Given this list of marker genes OTUD6B, EIF4E2, EIF4A2, EIF4G3, EIF4EBP3, NCBP2, NCBP2L, NCBP1, EIF4A1, EIF4B, EIF4H (eukaryotic translation initiation factor 4H), EIF4E1B, NCBP3, EIF4E3, EIF4G2, EIF4G1, EIF4E, here is a description of the gene set: Human Gene Set: GOCC_RNA_CAP_BINDING_COMPLEX A protein complex that binds to an RNA cap structure to mediate RNA processing and/or translation initiation. species: Homo sapiens